Given this list of marker genes Tlr7, Scimp, Tasl, D1Pas1, Slc15a4, Ptpn22, Havcr2, Rsad2, Treml4, Pik3ap1, Unc93b1, Ddx3x, here is a description of the gene set: The series of molecular signals initiated by a ligand binding to the endolysosomal toll-like receptor 7. species: Mus musculus Mouse Gene Set: GOBP_TOLL_LIKE_RECEPTOR_7_SIGNALING_PATHWAY